The following is a description of a gene set: Genes predicted to be targets of miRBase v22 microRNA mmu_miR_338_3p in miRDB v6.0 with MirTarget v4 prediction scores > 80 (high confidence targets). Mouse Gene Set: MIR_338_3P studied in species Mus musculus from publication Chen Y, Wang X (PMID 31504780), and this is the list of marker genes: Mmp12, Cyp2j5, Tpm3, Armcx3, Slc30a7, 1600012H06Rik, Mtus1, Canx, Fgfr2, Herpud2, Snap29, Rin2, Cacna1g, Ryk (receptor-like tyrosine kinase), Zfp942, Ets1, Crybg1, Kcnd2, Ide, Ppp4r1, Sec16a, Svs4, Trim33, Fktn, Actr2, Vsir, Rab14, Pea15a, Gpr20, Nol4, Dusp16, Lmo7, Ephx3, Paxbp1, Msi2, Phf20l1 (NCBI Gene Id 239510), Sox6, Terf2, Mrps10, Gdf10, Srgap3, Spag11b, Cfc1, Zbtb10, Dcaf12, Larp4, Map2 (NCBI Gene Id 17756), Arglu1, Hspa9, Herc3, Kndc1 (kinase non-catalytic C-lobe domain (KIND) containing 1), B4galt7, Fut1, Retreg1, Zfp275, Semp2l1, Zfp984, Tmem26, Thsd7a, Ptpn12, Tdrd3, Prrc2c, Mlkl, Crppa, Fbxw2, Chp1, Pcmtd2, Tnrc6b, Dip2c, Adamts20, Zdhhc21 (NCBI Gene Id 68268), Semp2l2a, Yju2b, Zfhx4, Wdr7, Sec61a2, Fam89b, Kansl1, Cacnb4, Camk2g, Zfp944, Zbtb18, Sh2d4a, Tbc1d15, Celsr2, Mafb, Yrdc, Septin8, Cdc25b, Camk2a, Zfp268, Pla2g3, Prex2, Nf2, 1110038F14Rik